Given this list of marker genes MPZ, TTC5, CLCNKA, PHEX, SCN2A, GAA, COL12A1, SDHB, CLCNKB, DOLK, KIDINS220 (NCBI Gene Id 57498), ITPR1, ALMS1, AHDC1, BSND, DLAT, ZNF407, DPM3, here is a description of the gene set: species: Homo sapiens A failure to achieve the ability to stand up at an appropriate developmental stage. Most children begin to walk alone at 11 to 15 months of age. On average, children can stand while holding on at the age of 9 to 10 months, can pull up to stand and walk with one hand being held at 12 months, and can stand alone and walk well at 18 months. Human Gene Set: HP_DELAYED_ABILITY_TO_STAND Delayed ability to stand